The following is a description of a gene set: SARS-CoV-2 Infection studied in species Homo sapiens Human Gene Set: REACTOME_SARS_COV_2_INFECTION, and this is the list of marker genes: NUP107, RPS3A (ribosomal protein S3A), NUP88, PATJ, PALS1, SFN, SEC23A, IL17F, MGAT2, SNRPB, ST3GAL1, ST6GALNAC3, IL17A, SDC3, RPS17, TPR, NUP153, IFNA7, RPS4Y2, CHMP6, ANO4, VPS33B, DDX5, AAAS, SDC2, ANO7 (anoctamin 7), ANO10, YWHAG, NLRP12, HLA-B, TBK1, STING1, VPS45, RPS11, IFNA13, AKT1, RIGI, ZDHHC20, DDOST, GOLGA7, STAT2 (NCBI Gene Id 6773), CNBP (CCHC-type zinc finger nucleic acid binding protein), SEC24A, RPS15, EDEM2, GEMIN7, NOD1, OSTC, GALNT1, G3BP2, TKFC, TLR2, NLRP3, CRB3, PARP8 (NCBI Gene Id 79668, poly(ADP-ribose) polymerase family member 8), PARP9, RPS27L, IFNA21, TOMM70, NUP58, RPS3, PARP16, UBE2I, PDPK1, RPS19, RNF135, SNRPG, SRPK2, HSP90AB1, RPS9, RPS18, IFNAR1, UBE2V1, PRMT1, RPS24, GEMIN5, HAVCR1, MGAT1 (alpha-1,3-mannosyl-glycoprotein 2-beta-N-acetylglucosaminyltransferase), RPS6, RPS14, SNRPE, GEMIN8, RPS27A, LARP1, NOD2, CHMP4A, HSPG2, RB1, POM121, RPS12, MASP2, CHMP2A, PARP4, STAT1, NUP98, RPS21, VPS33A, RAE1, IFNA4 (NCBI Gene Id 8006), IL17RC, UBE2N, CHMP2B, SEC24B, UVRAG, MGAT4B, SRPK1 (SRSF protein kinase 1), ZDHHC2, NUP214, TRAF6, IFNA5, GSK3A, MASP1, KPNA2, PIK3R4, VPS11, RPS28, NUP50, IFNA2, ANO8, YWHAH, GSK3B, ANO1, DAD1, GEMIN2, RPS4X (ribosomal protein S4 X-linked), HSP90AA1, SNRPD2, RPS4Y1, NUP93, RPS10, CHUK, CAV1, IRF7, ZDHHC11, NRP1, FUT8, IFNA14, ST6GAL1, IKBKB, NUP62, SEC24C, RPS26, ANO3, PTPN11, OST4, NUP54, CTSL, ST3GAL3, ZCRB1, TUFM, ZDHHC5, IKBKE, RPS15A, JAK1, RPS23, PARP10, IFNA8, BECN1, NUP160, VPS18, TLR7, MAP3K7, SMN1, PIK3C3, STT3B, NUP133, NUP42, SDC1, ANO5 (anoctamin 5), NDC1, SUMO1, MAP1LC3B, RANBP2 (RAN binding protein 2), GPC6, GJA1, IKBKG, PTPN6, UBB, FAU, PRKCSH, CSNK1A1, NUP35, MOGS, G3BP1, TLR1, YWHAB, RPS7, PARP14, MGAT5, MAN2A1, GEMIN4, MAVS, VPS16, VPS41, CHMP7, SEH1L, IFNAR2, SEC13, UBC, CHMP4B, NUP155, SEC24D, YWHAE, ANO6, RIPK2, HLA-F, RPS2, HLA-A, RPS20, IFNA6, ATG14, NUP37, PARP6, IRAK2, ISG15, FURIN, CANX, TRAF3, MAN1B1, CHMP4C, SNRPD3, TAB1, RPSA, RPS27, ST3GAL2, GANAB, TYK2, CHMP3, VPS39, RPN2, MBL2, NUP188, CREBBP, SNRPD1, SDC4, IFNA10, AKT3, IL17RA, TJP1, YWHAQ, SNRPF, TMPRSS2, AGRN, GPC4, ANO2, NUP205, SAR1B (NCBI Gene Id 56680), RPS13, GPC5, NUP210, AKT2, IFIH1, UBA52, GPC2, RPS29, ST6GALNAC4, MGAT4A, POM121C, TUSC3, IFNA17, HLA-E, IRF3, SFTPD, VHL, SIKE1, ZDHHC9, GPC1, HLA-C, ZDHHC8, TRIM4 (tripartite motif containing 4), RPS8, VCP, ST3GAL4, MGAT4C, HLA-G, STT3A, IFNA16, ZDHHC3, ST6GALNAC2, RPN1, TMEM258, GPC3, MAGT1, TAB2, DDX20, IFNB1, RPS16, RPS5, GEMIN6, YWHAZ, IRAK1 (NCBI Gene Id 3654), B2M, TAB3, SMN2 (NCBI Gene Id 6607), ACE2, ANO9, RPS25, IFNA1, TRIM25, NUP43, TLR8, ISCU, NUP85